The following is a description of a gene set: Human Gene Set: HP_ABNORMAL_CIRCULATING_SERINE_FAMILY_AMINO_ACID_CONCENTRATION Any deviation from the normal concentration of a serine family amino acid in the blood circulation. studied in species Homo sapiens Abnormal circulating serine family amino acid concentration, and this is the list of marker genes: SLC36A2, LIPT2, IBA57, SLC6A18, SLC6A20, SUCLG1, SLC25A13, COX8A, GLDC, MMUT, PSAT1, ATP5F1A, PCCA (NCBI Gene Id 5095), NFS1, AMT, PET117, SLC7A7, SLC30A10, SARDH, MMAA, PHGDH, PNPO, IRF6, ALDH4A1, PCCB, GLRX5, GCSH, NFU1, MMAB, SLC6A19, BOLA3, GLYCTK, PSPH